The following is a description of a gene set: from publication Sesto A, Navarro M, Burslem F, Jorcano JL (PMID 11867738) UV radiation is the most important environmental skin aggressor, causing cancer and other problems. This paper reports the use of oligonucleotide microarray technology to determine changes in gene expression in human keratinocytes after UVB treatment. Examination of the effects of different doses at different times after irradiation gave a global picture of the keratinocyte response to this type of insult. Five hundred thirty-nine regulated transcripts were found and organized into nine different clusters depending on behavior patterns. Classification of these genes into 23 functional categories revealed that several biological processes are globally affected by UVB. In addition to confirming a majority up-regulation of the transcripts related to the UV-specific inflammatory and stress responses, significant increases were seen in the expression of genes involved in basal transcription, splicing, and translation as well as in the proteasome-mediated degradation category. On the other hand, those transcripts belonging to the metabolism and adhesion categories were strongly downregulated. These results demonstrate the complexity of the transcriptional profile of the UVB response, describe several cellular processes previously not known to be affected by UV irradiation, and serve as a basis for the global characterization of UV-regulated genes and pathways. Human Gene Set: SESTO_RESPONSE_TO_UV_C4 Cluster 4: genes changed in primary keratinocytes by UVB irradiation. studied in species Homo sapiens, and this is the list of marker genes: CDK5, LY6D, EFR3A, IVL, PREP, ATP12A, ISG15, NMT1, TYMS, CD9, ABCD3, SNRPD3, ALDH1A3, RAD23B, SNRPA, SRSF9, DGKA, TNFRSF1A, DDX39A, MPRIP